The following is a description of a gene set: species: Homo sapiens Studies of gene regulation by oxygen have revealed novel signal pathways that regulate the hypoxia-inducible factor (HIF) transcriptional system through post-translational hydroxylation of specific prolyl and asparaginyl residues in HIF-alpha subunits. These oxygen-sensitive modifications are catalyzed by members of the 2-oxoglutarate (2-OG) dioxygenase family (PHD1, PHD2, PHD3, and FIH-1), raising an important question regarding the extent of involvement of these and other enzymes of the same family in directing the global changes in gene expression that are induced by hypoxia. To address this, we compared patterns of gene expression induced by hypoxia and by a nonspecific 2-OG-dependent dioxygenase inhibitor, dimethyloxalylglycine (DMOG), among a set of 22,000 transcripts, by microarray analysis of MCF7 cells. By using short interfering RNA-based suppression of HIF-alpha subunits, we also compared responses that were dependent on, or independent of, the HIF system. Results revealed striking concordance between patterns of gene expression induced by hypoxia and by DMOG, indicating the central involvement of 2-OG-dependent dioxygenases in oxygen-regulated gene expression. Many of these responses were suppressed by short interfering RNAs directed against HIF-1alpha and HIF-2alpha, with HIF-1alpha suppression manifesting substantially greater effects than HIF-2alpha suppression, supporting the importance of HIF pathways. Nevertheless, the definition of genes regulated by both hypoxia and DMOG, but not HIF, distinguished other pathways most likely involving the action of 2-OG-dependent dioxygenases on non-HIF substrates. Human Gene Set: ELVIDGE_HIF1A_TARGETS_UP Genes up-regulated in MCF7 cells (breast cancer) after knockdown of HIF1A by RNAi. from publication Elvidge GP, Glenny L, Appelhoff RJ, Ratcliffe PJ, Ragoussis J, Gleadle JM (PMID 16565084), and this is the list of marker genes: CHKA, RRP12, RPP25, SLC24A3, GDPD3, AUNIP, RRS1, SOBP (sine oculis binding protein homolog), GPATCH2, GULP1 (NCBI Gene Id 51454), OSTM1, ADAT1, CCND3, KPNA1, CORO1A, SPAG1, IDH3A, CHUK, POLR3K, CCDC86, HSPA4, ATP6V0A2, TOR3A, STX3, TAF9B, LSG1, MRPS12, HHEX, RFK, RAB35, RMC1, SLC25A44 (solute carrier family 25 member 44), URB2, JAK2, GLYR1, SRM, SCYL2, PSME3, TMEM33, SLC5A6, RRP15, LARS2, CTPS1, SLC29A1, SLC7A6, CXCL12 (C-X-C motif chemokine ligand 12), PSEN2, GYG1, GCH1, SEC23IP, DNAJA1, PNO1, GABBR2 (NCBI Gene Id 9568), SLCO3A1, ABCF2, WDR77, FASTKD5, SOCS2, SLC35B1, RIOX1, AREL1, AMD1, SLC35C1, IDE, RPP40, DOLK (dolichol kinase), HSPH1 (heat shock protein family H (Hsp110) member 1)